Given this list of marker genes PEX5, PEX14, PEX10, PEX12, PEX2, here is a description of the gene set: The process by which the cargo protein is released into the peroxisomal matrix, following translocation across the membrane. species: Homo sapiens Human Gene Set: GOBP_PROTEIN_IMPORT_INTO_PEROXISOME_MATRIX_SUBSTRATE_RELEASE